The following is a description of a gene set: Human Gene Set: WP_RETINOBLASTOMA_GENE_IN_CANCER studied in species Homo sapiens Retinoblastoma gene in cancer, and this is the list of marker genes: MYC, CDK4, CCNB2, MCM7, POLE2, SMC3, DNMT1, DHFR, HLTF, RB1 (NCBI Gene Id 92728), RBBP4 (RB binding protein 4, chromatin remodeling factor, NCBI Gene Id 91125), HMGB2, SMC2 (structural maintenance of chromosomes 2), SMARCA2, BARD1, SIN3A (SIN3 transcription regulator family member A), CDC25B, E2F1, SKP2, WEE1, SAP30, TYMS (thymidylate synthetase), ORC1, RFC5, POLD3, MIR29B2, ANLN, NPAT, RFC4, HDAC1, RPA3, PCNA, H2AZ1, CDC25A, SUV39H1, POLE, E2F3, PRKDC, MSH6 (mutS homolog 6), CDC7 (cell division cycle 7), PRIM1, MCM6, CCNA2, CDKN1A, SMC1A (structural maintenance of chromosomes 1A), MDM2, CCNE2, TTK, ABL1, TFDP2, MIR21, CCNB1, PLK4, RBBP7, CCND3, RFC3, CHEK1, ZNF655, MCM4, FAF1, MCM3 (NCBI Gene Id 4172), TOP2A, RBP1, FANCG, CDKN1B (NCBI Gene Id 1027), RABIF, TP53, PRMT2 (NCBI Gene Id 3275), STMN1, CDC45, POLA1, RPA2, MAPK13, CDK1, E2F2 (NCBI Gene Id 1870), CCND1, CCDC6, RPA1, DCK, TFDP1, KIF4A, CDT1, CDK2, CDK6, HMGB1, CCNE1, RRM2, RRM1, RAF1, MIR29B1